Given this list of marker genes OVOL2, FGFR2, HOXD13, SOX11 (SRY-box transcription factor 11), GLI3, SIX2, SHH, SMAD2, GATA4, NODAL, WNT5A, AHI1, NKX2-3 (NCBI Gene Id 53631), NCKAP1, GLI1, TP63, NOTCH1, IHH, AGR2, STRA6, ID2, PERCC1, NIPBL, RBPMS2, DACT1, EGFR, HOXA13, FGF10, PDGFRA, FOXF1, CTNNB1, SFRP2 (secreted frizzled related protein 2), WNT11, EPB41L5, BBS7, SHOX2, HNF1B, EPHB3, HLX, TP73, VANGL2, PITX2, HIF1A, SOX10, ACVR2B, TCF21 (NCBI Gene Id 6943), SFRP1, NPR2, BCL2, SFRP5, GLI2, SOX17 (NCBI Gene Id 64321), SMAD3, here is a description of the gene set: studied in species Homo sapiens The process in which the anatomical structures of the digestive tract are generated and organized. The digestive tract is the anatomical structure through which food passes and is processed. Human Gene Set: GOBP_DIGESTIVE_TRACT_MORPHOGENESIS